The following is a description of a gene set: Mouse Gene Set: GOMF_RNA_EXONUCLEASE_ACTIVITY Catalysis of the sequential cleavage of mononucleotides from a free 5' or 3' terminus of an RNA molecule. species: Mus musculus, and this is the list of marker genes: Polrmt, Pan2, Isg20l2 (NCBI Gene Id 97085), Xrn2, Eri2, Exosc10, Exd2, Rexo2, Pnldc1, Usb1, Toe1, Zc3h12a, Pnpt1, Eri3, Noct, Cpsf3, Eri1 (NCBI Gene Id 67276), Dcp2, Pde12, Dis3l, Dis3l2, Dis3, Cnot2 (NCBI Gene Id 97648), Myg1, Pan3, Cnot6l, Cnot8, Cnot6, Xrn1 (5'-3' exoribonuclease 1), Helz2, Cnot7, Isg20, Parn, Cnot1